The following is a description of a gene set: species: Homo sapiens Human Gene Set: HP_LARGE_FORAMEN_MAGNUM An abnormal increase in the size of the foramen magnum. Large foramen magnum, and this is the list of marker genes: RUNX2, GPSM2, FLNA, RAB23, CREBBP, EP300